Given this list of marker genes SMAGP, ARHGDIG, PGM5, ZNF324, PYCR3, KLRC3, CAMK1D, HERC6, SIGLEC7, IFNGR2, TAPBP, EMD, ENTPD6, RNPEPL1, LGR4, ST3GAL1 (ST3 beta-galactoside alpha-2,3-sialyltransferase 1), DENND4B, SLC48A1, H1-3, VPS13D, ASGR1, ANKEF1, ZNF696, LMNA, UBA7, REG1A, RPSA, CALML3, CRYL1, ENTPD1-AS1, IL11RA, ATF6B, PIP5K1B, PGGHG, BBC3, KDM5B, IFT88, MYCBP2, ARL6IP5, ABCA5, UBASH3A, SLA, EML2, KDM4C, RPL10A, TMEM109, MSN, ARHGEF5, RPS6KA2, AVPI1, ZFP36, KCND3, CTBP1, ID3 (NCBI Gene Id 3399), RBFOX1, TNFSF13 (NCBI Gene Id 8741), ARMH3, CHRNA9, CLEC4A, MTUS2, ANKZF1, GFER, WFS1, DGCR2, KANK3, H2BC21, NAGPA, ARSF, MAVS, HSPA1A, USP19, NRG2, DIDO1, SPRY1, B2M (beta-2-microglobulin), PDP1, EEF1G, ANXA4, ANGEL1, FHL1, KCNA3, EEF1B2, USP32, FBLN2, PLXNC1, DFFA, NOP53, PODXL2, TENT5A, GCK (glucokinase), POGLUT1, TPP1, TELO2, TH, NPC2, TOP6BL, JAM3 (NCBI Gene Id 84887), PCDH9, PPFIBP1, UBE2W, LDOC1, HSPA1L, GPR171, SPO11, H2BC7, RSAD1, RPL3, KLF8, ADARB1, ADA2, KDM2A, LIMS2, PAOX, RPL34, NDRG3, KRT17, SIGLEC9, FOXO4, MLLT1, TNFSF12, CERS6, SMC6 (structural maintenance of chromosomes 6), ROS1, ACAD10, SULT2B1, MTF1, TPST1, ETHE1, RUSF1, FIS1, HCK, GPR132, LIPE (NCBI Gene Id 3991), GOLGA2 (golgin A2), SAP30L-AS1, PLEC, FAM120C, ZNF671, TIMM50, LY6E, VAMP4 (vesicle associated membrane protein 4), NR4A1, TTPAL, TNNI1, FOXO3, LINC03124, PCBP4, GP1BB, DPH5, PARP16, RPS17, GAA, NDRG1, H4C11, SCNN1A, ZNF510, CRYAA, DOK2, IGKV3-20, TRIM22, ARHGAP24, IL6, TSPAN32, PECR, CABYR, MIA2, MIPEP, RNF126P1, TTC9, UBOX5, INPP5E, PDE8A, MAN2A2, ASIC2, NSA2, RAP1GAP2, GAK, ZNF337, GLT8D1, CHD1L, AMT, ABO, MPIG6B (NCBI Gene Id 80739), XKR8, DOHH, GBP2, AP2B1, SLC66A2, TCF20, H2BC6, ZSCAN9, GSE1, CIITA, DTNB, ZNF224, SLC4A5, here is a description of the gene set: from publication Longo NS, Lugar PL, Yavuz S, Zhang W, Krijger PH, Russ DE, Jima DD, Dave SS, Grammer AC, Lipsky PE (PMID 19023113) B cells from human tonsil and blood were sorted using flow cytometry. The human samples were processed immediately ex-vivo using markers for known B cell subsets. Human Gene Set: GSE12845_IGD_POS_BLOOD_VS_DARKZONE_GC_TONSIL_BCELL_UP studied in species Homo sapiens Genes up-regulated in comparison of IgD+ peripheral blood B cells versus dark zone germincal center B cells.